The following is a description of a gene set: studied in species Homo sapiens Human Gene Set: REACTOME_INTERLEUKIN_27_SIGNALING Interleukin-27 signaling, and this is the list of marker genes: STAT1, JAK1, CANX, CRLF1, IL6ST, STAT3, EBI3, IL27, TYK2, JAK2, IL27RA